Given this list of marker genes CLDND1, SLCO3A1, SIRPA (signal regulatory protein alpha), SIRT7, IFT81, HVCN1, NPLOC4, N4BP3 (NEDD4 binding protein 3), PRR13, AURKA, IRS2, NEK6, CDC42EP3, DNAJC21, MVB12A, TIMP1, OVOL2, PIAS2, FAM50A, MARVELD1, PC, B9D2, FBXO6, ATOSB, ARHGAP1, CIB1, SCHIP1, PLEC, L1CAM, ZNRF1, NCBP3, VKORC1, NRL, ABCD1, EIF2B2, NKAIN1, CD2, ENO2, GNPDA1 (NCBI Gene Id 9930), FBXO32, RACGAP1, TIPARP, EMP3, ZBTB18, IL9, FLII, TLE1, KCNJ5, RNF130, PLPPR4, CLDN16, PIK3CA, GTF2IRD1, MEF2B, CTLA4, RPS16, FKBP1A, KLF13, CCSAP, FANCI, PRNP, STK17B, COMP, PDCD6, TXK, SAE1, TSC22D4, SLC66A1, MYO1H, SUGT1 (SGT1 homolog, MIS12 kinetochore complex assembly cochaperone), CCR5 (NCBI Gene Id 727797), NPL, KLF10, CSF3, ARF6, DOK2, FA2H, ZYX, UBE2B, CTSC, CDH17, FUT9, AGTRAP, TNFRSF25, NUCB2, DOK3, SMAD1, ENTREP3, PHF13, TBC1D19, ST3GAL4, IL2RB, GALE, FMNL3, SEC61A1, MXI1, NAT8, SPOUT1, MTARC1, FRMD8, RAB1B, FOXA2, ACVRL1, EIF6, AP1G2, DENND10, ESPN, PMEPA1, TTC39B, ADAM9, GNAI3, SELENOW, LONP2, RHOG, SSNA1, ABCG1, S100A8, CHUK, HIF1A, LGALS3, ASF1B, MIS18A, SLC25A15, TAGLN2, TIAM1, TEX261, MAPK14, PREB, MFSD6, SEMA4D, ANP32A, MPI, DPAGT1, BOLL, ARAP1, UHRF1, UBXN1, HNRNPD, PLOD3, ERC1, SLC43A3, NAGK, KLKB1, ARSA (arylsulfatase A), SFRP5, SEPTIN9, SLC66A3, ARHGAP4, RNF19B, NHERF1, EPB42 (NCBI Gene Id 2038), VPS29, LDLRAP1, SAP30L, SGK1, TLE5, PRAF2, AEBP2, ALPG, CD6, DDA1, NCKAP1, CRMP1, DCAF15 (DDB1 and CUL4 associated factor 15), CHST3, STAT5B, LRBA, CISH, MAP3K3, RPS11, MTMR6, ARHGAP45, TSPAN5, ANXA4, HSPB1, EPB41L3, SERTAD1, FNDC3A, ABCC6, RELL1, MET (MET proto-oncogene, receptor tyrosine kinase), MYBL2, FABP6 (fatty acid binding protein 6), TMEM109, TST, WASHC2A, AP3D1, RALB, LRRC46, AFG2A, SMPD5, CDS2, ACTR1A, FURIN, P3H4, SERF2, GJA1, TSPO, LIME1, here is a description of the gene set: Human Gene Set: GSE15330_MEGAKARYOCYTE_ERYTHROID_VS_GRANULOCYTE_MONOCYTE_PROGENITOR_IKAROS_KO_DN Genes down-regulated in IKZF1 knockout: megakaryo-erythrocyte progenitors versus granulo-monocyte progenitors. from publication Ng SY, Yoshida T, Zhang J, Georgopoulos K (PMID 19345118) studied in species Homo sapiens Regulation of lineage potential and transcriptional priming by Ikaros. New insight is provided into a bivalent regulation of lineage priming in the HSC and its lympho-myeloid restricted progeny the LMPP by the lymphoid lineage-determining factor Ikaros Whereas Ikaros is responsible for the activation of a cascade of lymphoid expression programs and for the establishment of lymphoid potential from the HSC to the LMPP it is also responsible for the repression of stem cell and erythroid genetic programs that are incompatible with further lineage restrictions emanating from the LMPP